The following is a description of a gene set: Human Gene Set: MIR10226 from publication Chen Y, Wang X (PMID 31504780) Genes predicted to be targets of miRBase v22 microRNA hsa-miR-10226 in miRDB v6.0 with MirTarget v4 prediction scores > 80 (high confidence targets). species: Homo sapiens, and this is the list of marker genes: WDTC1, FIGN, WASF2, RXRG, RGS22, DOP1A, DENND6A (NCBI Gene Id 201627), BAZ1A, ATP11A, RIMS1, MED14, IGF2, CACNB1, TXNDC15, ADGRA1, OSBPL10, WARS2, AOPEP, NXT2, TSTD2, ZNF268, SNX2, RSPH4A (radial spoke head component 4A), DOK6, AKAP10, ARRDC3, EPHA5, SSBP2, SLC2A12, AIDA, TKFC, ZNF616, MAPK6, PPIL1, FBLIM1, ZNF439, TBC1D25, TMEM121B, HMGA2, FSBP, CDC14A, NXT1, AFF4, CCDC141, ZNF175, ANKDD1A, NEDD9, ATP2A2, ANKRD44, CWH43, SCARA3, PTPRT, HSF5, SLC13A1, SYT14, AKAP11, MARCHF7, SCYL2 (SCY1 like pseudokinase 2), EFNB2, MTX2, RAD54B, FBXO45, DENND3, BEND6, ZNF407 (zinc finger protein 407), ELAVL4, BRINP3, BTN1A1, ZNF605, BTBD3, SLC4A8, KCNAB1, ZNF511, C1GALT1C1, ZNF853, ZNF559, TRPS1, RTL3